The following is a description of a gene set: Human Gene Set: HP_ABSENCE_OF_SUBCUTANEOUS_FAT studied in species Homo sapiens Absence of subcutaneous fat Lack of subcutaneous adipose tissue., and this is the list of marker genes: MPLKIP (M-phase specific PLK1 interacting protein), POLR3A, TARS1, RNF113A (ring finger protein 113A), PRIM1, CAV1, KCNJ6, CARS1, ERCC4, PIK3R1, FBN1, ERCC3, ZMPSTE24, AARS1, GTF2E2, GTF2H5 (general transcription factor IIH subunit 5), ERCC2, LMNA